Given this list of marker genes TRPC5, CDH1, TP73 (NCBI Gene Id 7161), HSP90AA1, SLC12A2 (solute carrier family 12 member 2), ARHGAP5 (NCBI Gene Id 394), GSK3B, RGMA, MAPT, PTEN, ANAPC2, MAG, IL7R, SHTN1, SEMA4F, IQGAP3, SEMA6D, FSHR, BCL11A, CLCN3, SLC12A4, SRF, WNT5A, SMURF1, DSCAM, TRIM46, SCTR, MT3, FN1, NTN1, SEMA3A, MAP3K7 (NCBI Gene Id 6885), VAV2, KEL, MSN (moesin), GPRC5B, LIMK1, AMOT, NRP1, IST1, WNT3A, NRCAM, KCNMA1, SLC12A8, MTPN, LRRC8E, SEMA4D, RARG, SPP1, PUM2, SCT (secretin), SEMA6C (semaphorin 6C), MEGF8, MAP1B, DIP2B, ULK2, SEMA5A, CDK5, CCDC51, AQP11, TSC1, MAP2, CXCL12, BDNF, LAMTOR5, GNB3, RAC1, SPART, PLXNA3, OXSR1, KDM1A, RPTOR, CLNS1A, EZR, ABL1, WNK3 (WNK lysine deficient protein kinase 3), POU4F2, RYK, EPHA7, RTN4 (NCBI Gene Id 57142), L1CAM, SLC12A6, RUFY3, MACF1, STK39, ANO6, RTN4R, TNR, KIAA0319, SIN3A, AQP1 (aquaporin 1 (Colton blood group)), RET, PRR16, FSTL4, CDH4, XK, WDTC1, PAFAH1B1, DEPTOR, RNF6, TNFRSF12A, E2F4, BARHL2, ARHGAP4, SLIT1, RAP1GAP2, COL6A1, ADCY10, VAV1, SLC12A5, CLCN6, SLC12A1, ISLR2 (immunoglobulin superfamily containing leucine rich repeat 2), SLC26A5, EFNA5, CLN8, NKX6-1, PLEK, P2RX7, TWF2, NTRK3, CLN3, PRKD1, AKT3, DCC, FGF13, MAP3K13, ARHGAP35, SHANK3, BMPR2, CLASP2, LARS1, CDKL5, RB1CC1, NPM1, DRAXIN, WNK1, ZFYVE27, LPAR3, GOLGA4, RDX, VEGFA, IFRD1, RND2, ADNP, MTOR, AKT1S1, SEMA3F, DISC1, CTTN, PTPRS, GDI1, NHERF1, SLC12A9, TRPV4 (transient receptor potential cation channel subfamily V member 4), CAV3, LAMTOR4, CREB1, CFL1, CDKL3, ULK1, SLC12A3, SEMA7A, AQP4, VAV3, WNT3, PAK1, RHOA, RAB21, DNM2, UCN, PLXNA4, ABCB8, SLC12A7, CRABP2, HDAC6, OLFM1, APOE, LRRC8A, SEMA3G, TRPV2, KCNN4, EDN1 (endothelin 1), NGF, TTL, here is a description of the gene set: Any process that modulates the size of a cell. studied in species Homo sapiens Human Gene Set: GOBP_REGULATION_OF_CELL_SIZE